The following is a description of a gene set: part of: Transcriptional regulation by the AP-2 (TFAP2) family of transcription factors During retinoic acid-induced cell differentiation, TFAP2A, in complex with NPM1 (nucleophosmin), represses transcription of HSPD1 (Hsp60), NOP2 (p120) and MYBL2 (b-Myb). The repression of gene expression probably involves the recruitment of histone deacetylases HDAC1 and HDCA2 to target promoters by NPM1. The complex of TFAP2A and NPM1 can also be detected at the NPM1 promoter, which is in agreement with decreased NPM1 expression after retinoic acid treatment. The level of TFAP2A increases in response to the retinoic acid treatment. NOP2 and MYBL2 are both proliferation markers. Reactome Pathway: TFAP2A acts as a transcriptional repressor during retinoic acid induced cell differentiation studied in species Homo sapiens, and this is the list of marker genes: HSPD1, MYBL2, NOP2, NPM1, TFAP2A